The following is a description of a gene set: Reactome Pathway: Methylation of MeSeH for excretion species: Homo sapiens Methylselenol (MeSeH) is further methylated to dimethylselenide (Me2Se) and trimethylselenonium (Me3Se+) for excretion. part of: Selenoamino acid metabolism, and this is the list of marker genes: INMT